The following is a description of a gene set: studied in species Homo sapiens A mental disorder characterized by a disintegration of thought processes and emotional responsiveness. It most commonly manifests as auditory hallucinations, paranoid or bizarre delusions, or disorganized speech and thinking. It is accompanied by significant social or occupational dysfunction. The onset of symptoms typically occurs in young adulthood, with a global lifetime prevalence of about 1%. This term is not a helpful parent term to describe abnormal experiences. Schizophrenia Human Gene Set: HP_SCHIZOPHRENIA, and this is the list of marker genes: LRRK2, SNCA, SYN2, PSAP, MSTO1, HARS1, CEP78, APOL4, HIRA, SHANK3, DRD3, ESPN, CHRNA7, PCDH15, WFS1, ABCB7, MED12, GJA8, EIF4G1, CIB2, ZBTB20, USH2A, COMT (catechol-O-methyltransferase), CHI3L1, ATG7, PRODH, KRT83, USH1G, VPS35, CLRN1, CNTNAP2, CAT, GBA1, NKX2-1, GIGYF2, UPF3B, ARVCF, ZDHHC9, DSG4, USH1C, RBM12, NIPA2, KRT86, RREB1, DAOA, SETD1A, ARSG, ARSA, MT-TS2, WHRN, SLC12A2, PDZD7, APOL2, SEC24C, AMACR, DNAJC13, MYO7A, JMJD1C, TPM2, GP1BB, HTR2A, FLI1, KRT81, RTN4R, UFD1, GJA5, TUBG1, FTSJ1, TBX1, ADGRV1, NIPA1, DNMT3A, CDH23, MTHFR, MT-TE, ATP2A2